The following is a description of a gene set: part of: Platelet calcium homeostasis Activation of non- excitable cells involves the agonist-induced elevation of cytosolic Ca2+, an essential process for platelet activation. It occurs through Ca2+ release from intracellular stores and Ca2+ entry through the plasma membrane. Ca2+ store release involves phospholipase C (PLC)-mediated production of inositol-1,4,5-trisphosphate (IP3), which in turn stimulates IP3 receptor channels to release Ca2+ from intracellular stores. This is followed by Ca2+ entry into the cell through plasma membrane calcium channels, a process referred to as store-operated calcium entry (SOCE). Stromal interaction molecule 1 (STIM1), a Ca2+ sensor molecule in intracellular stores, and the four transmembrane channel protein Orai1 are the key players in platelet SOCE. Other major Ca2+ entry mechanisms are mediated by the direct receptor-operated calcium (ROC) channel, P2X1 and transient receptor potential channels (TRPCs). Reactome Pathway: Elevation of cytosolic Ca2+ levels studied in species Homo sapiens, and this is the list of marker genes: P2RX2, ITPR1, ORAI1, P2RX3, TRPC6, ORAI2, ITPR3, P2RX4, TRPC7, P2RX1, ITPR2, STIM1, TRPC3, P2RX6, P2RX5, P2RX7